The following is a description of a gene set: species: Homo sapiens The assembly and organization of the sperm mitochondrial sheath, the tightly packed helical sheath of ATP-producing mitochondria restricted to the midpiece of the sperm flagellum. Human Gene Set: GOBP_SPERM_MITOCHONDRIAL_SHEATH_ASSEMBLY, and this is the list of marker genes: ARMC12, LRRC46, CFAP58, KLC3, VDAC3, TBC1D21, GK2